The following is a description of a gene set: Mouse Gene Set: GOBP_PROTEIN_EXIT_FROM_ENDOPLASMIC_RETICULUM species: Mus musculus The directed movement of proteins from the endoplasmic reticulum., and this is the list of marker genes: Hsp90b1, Rangrf, Slc35d3, Herpud1, Erlec1, Sec61bl, Sec16b, Ufd1, Derl3, Nploc4, Ube2j1, Sec16a (SEC16 homolog A, endoplasmic reticulum export factor), Yod1, Derl2, Sec13, Mia2, Bcap31, Slc51b (NCBI Gene Id 330962), Svip, Edem2, Vcp, Edem1, Derl1, Gcc2, Afg2b, Tecpr2, Os9, Rhbdd1, H13, Sec61b, Steep1, Ube2g2 (NCBI Gene Id 68471), Cd81, Sorl1, Insig1, Tmem30a, Tm9sf4, Tmem30b, Syvn1, Sel1l, Faf2, Tmem129, Selenos (NCBI Gene Id 97368), Aup1, Ubac2